Given this list of marker genes Irgm2, Igtp, Sqstm1, Lamp2, Clu, Hspa8, Smurf1, Irgm1, here is a description of the gene set: Mouse Gene Set: GOBP_PROTEIN_TARGETING_TO_VACUOLE_INVOLVED_IN_AUTOPHAGY species: Mus musculus The process of directing proteins towards the vacuole using signals contained within the protein, occurring as part of autophagy, the process in which cells digest parts of their own cytoplasm.